Given this list of marker genes Bcl3, Socs3 (suppressor of cytokine signaling 3), Serinc3, Fkbp5, Ccnd3, Zfp36l2, here is a description of the gene set: studied in species Mus musculus from publication Cui A, Huang T, Li S, Ma A, Pérez JL, Sander C, Keskin DB, Wu CJ, Fraenkel E, Hacohen N (PMID 38057668) Genes positively differentially expressed in cell type: B cell upon treatment with cytokine: IL-1β in mouse lymph nodes in vivo. Mouse Gene Set: CUI_B_CELL_IL1B_RESPONSE_UP Cytokines mediate cell-cell communication in the immune system and represent important therapeutic targets. A myriad of studies have highlighted their central role in immune function, yet we lack a global view of the cellular responses of each immune cell type to each cytokine. To address this gap, the authors created the Immune Dictionary, a compendium of single-cell transcriptomic profiles of more than 17 immune cell types in response to each of 86 cytokines (>1,400 cytokine-cell type combinations) in mouse lymph nodes in vivo. A cytokine-centric view of the dictionary revealed that most cytokines induce highly cell-type-specific responses. For example, the inflammatory cytokine interleukin-1β induces distinct gene programmes in almost every cell type. A cell-type-centric view of the dictionary identified more than 66 cytokine-driven cellular polarization states across immune cell types, including previously uncharacterized states such as an interleukin-18-induced polyfunctional natural killer cell state.